Given this list of marker genes RDH8 (NCBI Gene Id 50700), HSD17B12, HSD17B2, AKR1B15, HSD17B8, HSD17B7, HSD17B1, DHRS11, HSD17B11, CYP19A1, HSD3B1, here is a description of the gene set: species: Homo sapiens Human Gene Set: GOBP_ESTROGEN_BIOSYNTHETIC_PROCESS The chemical reactions and pathways resulting in the formation of estrogens, C18 steroid hormones that can stimulate the development of female sexual characteristics. Also found in plants.